Given this list of marker genes SLC18B1, SLC22A1 (solute carrier family 22 member 1), SNCA, SLC22A3, GPM6B, SLC29A4, NOS1, SLC18A1, ITGB3, SLC22A2, SLC18A3, SLC18A2, SLC6A4, here is a description of the gene set: The directed movement of serotonin into a cell, typically presynaptic neurons or glial cells. Serotonin (5-hydroxytryptamine) is a monoamine neurotransmitter occurring in the peripheral and central nervous systems. studied in species Homo sapiens Human Gene Set: GOBP_SEROTONIN_UPTAKE